Given this list of marker genes SULT1E1, CCNB2, SLC16A9, WDR45, MYMK, ARHGEF3, CAMK4, NCDN, CEP83-DT, KCTD12, SLC10A3 (NCBI Gene Id 8273), NQO2, SPP1, SH2D2A, ADGRG5, MED7, MAN2C1, CHAF1B, NSUN7, DOCK2 (dedicator of cytokinesis 2), ATP6V1F, DBF4, UBL5, TXNL4A, TRAIP, ZDHHC3, TRIM21, PLEKHA6, COX7A1, EIF2AK2, IRAG2, CLDN18, FOXP1, ZNF124, MMP10, IL16 (interleukin 16), STARD3NL, DYNLRB1, S100A6, AK3, CD96, RFC4, ARHGDIB, PON1, PLEKHM2, GBP2, ADD3, CDK16, MEF2A, RAP1GAP2, UBXN8, H1-4, URM1, OPLAH, KIF23, LIME1, OVOL1, HAUS7, FBXO41, ALKBH6, MYL12B, RBM44, DSCC1, EXOC3L4, GCC1, TRDMT1, GSTZ1, PHYHIPL, FAM110B, IRS1, TMEM25, PHTF1, ASF1B, ZMAT5, ZNF646, PRKAB1, PLAAT3, AKIP1, LAD1, EEIG2, MUTYH, GRM2, WBP1L, KLRK1, PPM1N (protein phosphatase, Mg2+/Mn2+ dependent 1N (putative)), ZNF565, LANCL2, DDB2, CC2D1B, ADAMTS16, NUDT15, IPCEF1, HCRT, TACC2, IRGM, VEGFD, MCTP2, NAAA, NEDD8, ZBTB8OS, TUB, RIMS3, ARMC7, DUSP26, NSMCE2, GRAMD1C, NMU, BRD9, PDGFRA, TSHZ1, EPHA1, NCKIPSD, NCOA5, HEXIM1, GPSM3, FGFR1OP2, HJURP, PKDREJ, CAMK2N2, TST, DENND2A, DDX28, CNDP2, POPDC3, ATP6V1C2, CTDSP1, SCFD2, VGF, XCL1, MED11, ADH4, NR0B1, MAN2B1, HYAL4, H1-6, GGH, TRIOBP, CHRNA4, ATOH1, TPSG1, S100A11, RASGEF1C, PRM3, NRN1, TBX21, ADGRE5, RBM6 (RNA binding motif protein 6), LSM10 (NCBI Gene Id 84967), LONP2, DCDC2, GTSF1L (gametocyte specific factor 1 like), GPRC5A, BTG2, GABPB2, ST14, NTN5, OSBPL5, LGALS9B, TP53I11, RNASE10, ABHD10, MTHFSD (methenyltetrahydrofolate synthetase domain containing), MSI1, GIP, SOX2-OT, SDR39U1, ME3, VPS33B, SEPTIN1, THSD1, KCNK16, PMM2, NSFL1C, SMC5, TSNAXIP1, INPP5B, FCGR3A, STAT1, TMEM184C, C3orf22, IRF2, FGL2, ATP5ME, SH3GLB1, UBE2S, B4GALNT1, SREBF1, PARP2 (poly(ADP-ribose) polymerase 2), SCYL3, GUCY2D, ABL1, PIGT, CLMN, GDPD5, ARPC1B, FXYD5, HESX1, HSD17B11, PTEN, here is a description of the gene set: Transcription factors that regulate quiescence, proliferation, and homing of lymphocytes are critical for effective immune system function. In the present study, we demonstrated that the transcription factor ELF4 directly activates the tumor suppressor KLF4 downstream of T cell receptor (TCR) signaling to induce cell cycle arrest in naive CD8+ T cells. Elf4- and Klf4-deficient mice accumulated CD8+CD44hi T cells during steady-state conditions and generated more memory T cells after immunization. The homeostatic expansion of CD8+CD44hi T cells in Elf4-null mice resulted in a redistribution of cells to non-lymphoid tissue due to reduced expression of the transcription factor KLF2, and the surface proteins CCR7 and CD62L. This work describes the combinatorial role of lymphocyte-intrinsic factors in the control of T cell homeostasis, activation and homing. from publication Yamada T, Park CS, Mamonkin M, Lacorazza HD (PMID 19412182) Genes down-regulated in comparison of activated CD8 T cells from ELF4 defficient mice versus those from wild type animals. Human Gene Set: GSE15324_ELF4_KO_VS_WT_ACTIVATED_CD8_TCELL_DN species: Homo sapiens